Given this list of marker genes Lamtor1, Slc38a9, Lamtor3, Lamtor4, Rragc, Flcn, Lamtor2, Lamtor5, Rraga, Fnip2, here is a description of the gene set: Mouse Gene Set: GOCC_GTPASE_ACTIVATOR_COMPLEX A protein complex which is capable of GTPase activator activity. species: Mus musculus